The following is a description of a gene set: Any microtubule that is part of a mitotic spindle; anchored at one spindle pole. species: Homo sapiens Human Gene Set: GOCC_MITOTIC_SPINDLE_MICROTUBULE, and this is the list of marker genes: CLTC, HAUS4, HAUS1, TUBG1, CEP295, EML3 (EMAP like 3, NCBI Gene Id 256364), HAUS8, HAUS6, HNRNPU, MAPRE1, SKA1, HAUS3, HAUS5, HAUS2, MAP1S, HAUS7